The following is a description of a gene set: Mouse Gene Set: GOMF_TBP_CLASS_PROTEIN_BINDING species: Mus musculus Binding to a member of the class of TATA-binding proteins (TBP), including any of the TBP-related factors (TRFs)., and this is the list of marker genes: Nr3c1, Brf1, Hnrnpf, Esr1, Psmc2, Nkx2-1, Ruvbl2, Nr3c2, Ahr, Brf2, Psmc5, Gtf2b, Thra, Naca, Psmc1, Gtf2a2, Drap1, Taf1, Cand1, Cand2, Yeats2, Taf11, Gtf2a1, Rnf4, Dr1, Taf12, Utf1, Ruvbl1, Taf13